The following is a description of a gene set: from publication Chen Y, Wang X (PMID 31504780) species: Homo sapiens Human Gene Set: MIR1468_3P Genes predicted to be targets of miRBase v22 microRNA hsa-miR-1468-3p in miRDB v6.0 with MirTarget v4 prediction scores > 80 (high confidence targets)., and this is the list of marker genes: MBTD1, SLCO1C1, SETD7, RBMS2, GPM6B, PTBP1, MAN1A1, CAMSAP1 (calmodulin regulated spectrin associated protein 1), DCLRE1C, LRP6, CACNA2D1, NIPAL1, ZNF418, RPS6KA5, ZKSCAN4, PEX5L, CEBPA, ZNF24, BTF3L4, BMPR2, NIN, FOXJ3, ACTL6A, TAFA5, ROR1, GCLM, CREBRF, EOGT, MED13L, LRRC39, FKBP4, CCAR1, ACBD5, PYHIN1, TMCC3, CHIC1, RBMS1, MEF2A, KCNMA1, IL1A (interleukin 1 alpha), PSD3, DCK, PRSS23, CASTOR2, TAOK1, PFKFB3, RGS20, CERT1, TFCP2L1, TBCEL, FNDC3B, ARMCX2, EBF1, SLC16A7, SENP1, TRIM33, SORBS1 (sorbin and SH3 domain containing 1), NFKBIZ, HOOK1 (hook microtubule tethering protein 1), PPM1D (protein phosphatase, Mg2+/Mn2+ dependent 1D), PDIK1L, TENT2, UCP3, CPNE4, WDFY3, ZFP28, TMEM9B, LAMP1, HS3ST5, VDAC1, GOLPH3, SMCR8, SPTSSB, FUT4, PRIM2, LMOD1, CLIP1, ZMYND11, PIK3CB, KCNE1, AKIRIN2, LHX8, BMPR1B, AP1S2, IREB2, AGFG1, JAK2, AFTPH, DNAJB14, ELMOD2, FOXP1, PHC3, TNFSF13B, KCTD8, MID1, KMT2C, PCGF6, TMEFF2, TENT5B, CBX6, AMIGO2, DSG2, MAPK8, ARFIP1, GTF2H5, LRIG2, CADPS, PRMT8, RPS6KB1, SPRY2, CCDC175, SV2B, B3GNT2, FILIP1, PDE5A, PAK5, ZBTB41, RPS6KA3, GPR85, MAT2B, INSIG1, TRAF6, CTNNB1, FAM76B, EXOC2, ANKRD11, APOB, CNTN1, FLVCR1, SEC23A, PRDM16, NEURL1B, TENM1, LSM14B, GABRA1, TMX3, SMIM13, VAMP3, HRK, PLEKHF2, CDH11, SLC30A4, DICER1, AGO4, DPM1, WIZ, CDCA8, THSD7A, ACSL6, MYBL1, OPCML, HNRNPLL, GLUD2, SESN3, DBN1, IGFBP3, CNKSR2, LHFPL2, C5orf24, EGR4, GIMAP7, SLC9C1, PPP2R5E, REEP3, SMURF2, CTTNBP2, CSMD3, CLEC3A, TACC1, PLSCR1, TAT, SPTY2D1, SLC38A1, NOXRED1, BCAT1, JADE1, USP13, ALG2, SGMS1, FBXW11, C11orf96 (NCBI Gene Id 387763), IPMK, E2F8, MPRIP, KLC4, CNTN5, SORBS2, MOSMO, OLFM3, CALHM4, NCDN, BOLA3, MAP1B, EIF4E (eukaryotic translation initiation factor 4E), VPS13B (vacuolar protein sorting 13 homolog B), ZNF345, RASSF5, TRIO, LRRFIP1, CDH7, SSR1, LONRF3, CD47, ANOS1, PIK3CA, PLXDC2 (NCBI Gene Id 84898), NDUFC1, NLGN4X, SHANK1, RRAGD, FUT9 (NCBI Gene Id 10690), SLC2A13, ZNF518A, BNIP2, MED12L, USP9X, STOX2 (storkhead box 2), STXBP5, TMEM170B, MSANTD4 (Myb/SANT DNA binding domain containing 4 with coiled-coils), ZDBF2, PAIP1, SFRP2, PPTC7, EPS8, LEF1, MYT1L, ELOC, RAPH1, ZNF813, APH1B, ZNF26, CAND1, TIMP3 (NCBI Gene Id 7078), AMMECR1, ITSN1, GCC2, PTAR1, BPTF, ELOVL5, TFRC, HBP1, SLC25A15, MSL2, CPEB2, CCNL2, SLC26A7, FGF14, ZNF148, SEC22B, PKN2, GLS, ARAP2, GPR6, GCFC2, PLCB1, PRR5L, UNK, RBBP8, ZBTB18, CBLN2, PDCD10, CDYL2, SOX6, RASGEF1C, C1GALT1C1L, GLIS3, EPC2 (NCBI Gene Id 96643), GCOM1, LDLR, EXOC5, PCDHGA7, WDR33, PLXNA2, COMMD10, NDFIP2, ANGPT1, G0S2, ZDHHC21, NRXN1, FSTL1, PFDN4, ARHGAP12, PRKAR2B, FAM13B, PPM1B, DSP, GATA2, DNAJC16, TNFRSF19, KLF7, LSM12, IRF2BP2, GABRA4, CCNL1, FZD6, NUP205, H2AZ1, MREG, COG6, ID3, PHTF2, TPD52L3, SCLT1 (sodium channel and clathrin linker 1), RBL2, NEXN, MYNN, CFL2, GLUD1, CNNM4, RMND5A, RICTOR, SRPK2, TRIM2, PDS5A, STXBP6, DCAF10, JCAD, SCN3A, CYLD, CR1 (complement C3b/C4b receptor 1 (Knops blood group)), PJA2, C3orf52, APPBP2, XYLT1, TESPA1, GABPB1, VSTM2B, ST8SIA4, RFX7, VKORC1L1, NAA25, MAPK9, TSHZ3, ATAD2B, KLF4, HECW2, HOXA9, FSD2, IL11, CCND2 (NCBI Gene Id 894), SVEP1, CD44, TMEM267, OOSP2, LDB3, ELAVL1, ERBB4, RDX, SRSF7, DTD2, MFSD14B, IGF2R, DACH1, CBFB, SEL1L, PRKCI, KCNQ5, NCKAP5, MTF1, PSME4 (NCBI Gene Id 23198), TCF4, PLXNA4, TTC9, PPP3CB, VPS36, MEF2C, NETO1, LAMTOR3, MAF, ZBTB39, CACNA1C, SCN9A, SRSF1, SLC12A2, SNX17, DMD, ADGRA2, PRKAR1A, PAX9, NANP, USP31, ATG14, C1GALT1C1, KCMF1, PREPL, ARMC1, LYPLA1, FANCA, TMTC1, RHAG, GPATCH2L, CTDSPL2, USF3, MATN3, MICAL2, FAM117A, MIER1, RHOXF2B (Rhox homeobox family member 2B), RHOXF2, DENND4C, SALL1, KCNC2, POLR2M, TMOD3 (tropomodulin 3), MAL2, CEP350, ARPP19, SRBD1, EDEM1, JAKMIP1, AMMECR1L, GPBP1L1, STK32A, LRIG3, RARG, FXR1, ANK3, SENP2, TIPARP, PIAS2, DMRT1, ANKRD42, MAP3K20, NUP58, CTNND1, RIMS2, KPNA6, ARMH4, UTS2, RNF145, EREG, HDX, UBR5, FIGN, WNT10A (NCBI Gene Id 93651), VEGFA, S1PR1, TNPO1, EIF2S2 (eukaryotic translation initiation factor 2 subunit beta), ARHGEF7, TSC1, PHLDB2, DCX, SHCBP1, FAT4, GABRB2, FAM120A, RCOR3, DDHD2, ASAP2, TNKS, ROBO1, PRKCA, OPTN, ZNF407, HELZ, ZMAT3, PRKAA1, KCNJ3, SPOPL, STRN3, GXYLT1, ITPRIPL2, PPP1R15B, LIN7C, DPP10, GRM7, SECISBP2L, PERP, C1RL (complement C1r subcomponent like), SLC4A7, MCC, ESR1, ZNF10, IP6K2, WNK3, PUM1, PAPPA (pappalysin 1), GAREM1, COL5A2, TSHZ2, FOXN3, CLIP4, DNAAF9, ONECUT2, TOR1A, GSKIP, MLLT3, NFATC1, ZNF704, RBPMS2, NF1, SLC5A3, MBNL2, FAM135A, BMP2K, RBM25, CBR4, ZNF598, PKHD1, TASOR2, STRN (NCBI Gene Id 6801), SLC6A15, DLG2, KBTBD8, WDR45B, ZNF367, TLR1, RAB21, ANKRD63, MSN, GNA13, SCAF11, ANO4, FBXO8, HCFC2, KCNJ2, KTN1 (NCBI Gene Id 8109), CNOT6L, RAB23, GRIK1, PRPF39, HOMER1, GSPT2, IBTK, CHMP2B, RASSF3, PPA1, CGGBP1, TRA2B, MCUR1, VGLL3, SNX13, IL18R1, CLVS2 (clavesin 2), GEM, ECT2, NFIB, VPS35, NAP1L5, SPTLC2, GTPBP3, WDR44, SOCS2, CEACAM7, MKRN1, WASL, ANKRD46, SCP2, IMPA1, VPS29, KLHL20, PLK4, NRP2, INTS6, SEPTIN8, ATF2, PARP9, LEPR, SLC1A6, GRAMD1A, CCDC91, CTDP1, NBR1, VPS26A, SYNM, IL1R1, UPF2, LCOR, GALNT18, NFAT5, CUL5, UNC80, STK26, TRIL, TMPRSS12, GSPT1, RUNX1T1, CSMD1, NKX3-1, HNRNPR (NCBI Gene Id 10236), SMU1, CEP55, ZNF680, TENT4B, ZBTB11, UHRF2, SGCB (sarcoglycan beta), BMP3, LCLAT1, COX8C, PHIP, EGLN1, MTMR6, ZNF740, MGAT2, DENND6A, TULP4, MECOM, SF3B4 (splicing factor 3b subunit 4), CAB39, C14orf28, EPHX4, NECTIN3 (NCBI Gene Id 25945), REEP1, SOX4, BTBD7, ZEB2, PSAP, GIT2, TMEM45A, PDCD6IP, SNIP1, ROBO2, SMAD5, TCEA1, TAF4, CST9, FOXJ2, ZNF217, HLF, PGRMC1, SLC35A5, MRTFB, LSM8, EPS15, ESRRG, KCNA4, PELI2, NUFIP2, SKIL, RPE65, MYSM1, YY1, PCGF5, ANKRD44, N4BP2, CHUK (NCBI Gene Id 1147), SPART, CCNO, TMED5, CLIC4, IL17A